Given this list of marker genes Rpl3, Psmc6, Rpl37rt, Rpl38, Ube2d1, Psmc4, Psmc1, Rpl18a, Rps27a, Rpl27a, Psmc5, Ubb, Rpl14, Psma4, Rpl24, Rpl37, Psma1, Rpl3l, Rpl23a, Psma3, Rpl36al, Psma6, Rpl37a, Rpl19, Psma2, Psmb5, Rpl13, Klhdc10, Rpl36a, Psmb7, Rpl39l, Rpl18, Psma7, Psma5, Rpl26, Rpl9, Rpl27, Rpl4, Rpl39, Psmc3, Psmb4, Psmd7, Rpl29, Psmc2, Psmd12 (NCBI Gene Id 66997), Psmb6, Rplp2, Rpl11, Rpl7, Psmd6, Rpl15, Rchy1, Rpl12, Rpl6, Psmd1, Psmd13, here is a description of the gene set: part of: Ribosome-associated quality control electronically inferred by orthology from the curated human pathway This event has been computationally inferred from an event that has been demonstrated in another species.<p>The inference is based on the homology mapping from PANTHER. Briefly, reactions for which all involved PhysicalEntities (in input, output and catalyst) have a mapped orthologue/paralogue (for complexes at least 75% of components must have a mapping) are inferred to the other species. Reactome Pathway: Ribosome Quality Control (RQC) complex extracts and degrades nascent peptide species: Mus musculus